The following is a description of a gene set: studied in species Mus musculus Genes predicted to be targets of miRBase v22 microRNA mmu_miR_3093_5p in miRDB v6.0 with MirTarget v4 prediction scores > 80 (high confidence targets). from publication Chen Y, Wang X (PMID 31504780) Mouse Gene Set: MIR_3093_5P, and this is the list of marker genes: Mfsd14b, Myo15a, Naa30, Adamts17, Cttnbp2nl, Psma1, B4gat1, Hoxc13, Tysnd1, Slc41a1, Garre1, Pramel1, Gnaq, Fyn, Ceacam5, Pard6b, Gjd2, Mterf4, Spred3, Mgrn1, Tulp4, Kank4, Tab1 (NCBI Gene Id 66513), Ttyh3, Herc2, Gtf2h1, Ctnnd1, Pcdh9, Kcnt1, Gramd1a, 0610030E20Rik, Ppp4r2, Macroh2a2, Tmem186, Plek